The following is a description of a gene set: Mouse Gene Set: GOBP_RESPONSE_TO_INTERFERON_ALPHA species: Mus musculus Any process that results in a change in state or activity of a cell or an organism (in terms of movement, secretion, enzyme production, gene expression, etc.) as a result of an interferon-alpha stimulus. Interferon-alpha is a type I interferon., and this is the list of marker genes: Axl, Oas1f, Tpr, Oas1g, Star, Adar, Myc, Ifitm3, Plscr1, Eif2ak2, Ifit2, Ifi204 (NCBI Gene Id 15951), Traf3ip3, Oas1e, Ifitm1, Gas6, Oas1b, Bst2, Oas1a, Ifitm2, Gata3, Oas1c, Oas1d, Ifnar2, Lamp3, Ifit1 (NCBI Gene Id 15957), Pde12, Ifnar1, Ro60, Ifitm6, Ifitm7, Oas1h, Tgtp1